Given this list of marker genes CD86, TRIM55, TNFSF14, PDCD4, TRIM44, EDA (ectodysplasin A), NMI, SASH1, LGALS9, MAP3K7, HMGB1, TNF, HAVCR2, MIR182, IFI35, PHB1, DDX3X, RHOA, IL23A, RELA, NLRP12, NR3C2, TERF2IP, SPHK1, AGER, TRIM26, TNFSF11, ZNF268, LRRC19, IL1B, IL18R1, RIPK1, VCP, RTKN2, LAPTM5, TRIP6, RC3H2, NOD1, TNFRSF11A, EIF2AK2, RBCK1, APP, RPS3, TRIM56, IL18, NLRP3, C1QTNF4, ACTN4, AGO3, PYCARD, CALR, EDN1, CD27, EDAR, CCL19, PTP4A3, TCIM, ADISSP, PHB2, GREM1, AGO1, NOD2, RC3H1, IL12B, TREM2, here is a description of the gene set: studied in species Homo sapiens Human Gene Set: GOBP_POSITIVE_REGULATION_OF_NON_CANONICAL_NF_KAPPAB_SIGNAL_TRANSDUCTION Any process that activates or increases the frequency, rate or extent of the non-canonical NF-kappaB cascade.